The following is a description of a gene set: species: Mus musculus Mouse Gene Set: GOBP_GLYCEROLIPID_BIOSYNTHETIC_PROCESS The chemical reactions and pathways resulting in the formation of glycerolipids, any lipid with a glycerol backbone., and this is the list of marker genes: Mppe1, Lpin3, Pik3cg, Ptprq, Etnk2, Pik3cb, Pip4k2b, Sh3glb1, Pigk, Gpat4, Pigt, Dgkg, Apoa2, Ang, Pigc, Apoa1, Dhrs7b, Pip5k1a, Pigx, Pgap1, Lpcat1, Gpld1, Agpat1 (1-acylglycerol-3-phosphate O-acyltransferase 1), Pla2g5, Nr1h3, Agpat3, Ang6, Pigq, Pigw, Ajuba, Pla2g4a, Pck1, Itpka, Alox15 (arachidonate 15-lipoxygenase), Itpkb, Cds2, Rgn (regucalcin), Dgka, Hycc1, Pign, Srebf1, Pdgfa, Mfsd2a, Capn2, Lpin2, Mogat1, Ttc7b, Ptdss1, Tmem150a, Pi4kb, Chkb, Acsl4, Fabp5, Sirt1, Pigg, Lpcat2, Pigm, Plpp1, Pi4k2b, Pld2, Pi4ka, Uvrag, Cds1, Awat2, Itpkc, Dgat1, Mogat2, Piga, Ip6k1, Pigl, Pigh, Pik3r4, Ang5, Dpm3, Far1 (fatty acyl CoA reductase 1), Slc27a1, Abhd8, Etnk1, Pik3c2a, Hdhd5, Pik3ca (NCBI Gene Id 70742), Mboat7, Ldlr, Pcyt1a, Dagla, Agmo, Atm, Crls1, Agpat4, Acsl5 (NCBI Gene Id 71879), Abhd5, Ctdnep1, Efr3b, Gpaa1, Pigo, Pik3r1, Plcg2, Inpp4a, Pgap2, Pdgfb, Pcyt2, Avil, Pyurf, Htr2a, Slc30a5, Thrsp (NCBI Gene Id 21835), Pla2g6, Inpp1, Dgkd, Tcf7l2, Pip4k2c, Scarb1, Pnpla3, Pi4k2a, Lpin1, Pigf, Dgkh, Pisd, Pik3c2b, Lclat1, Selenoi, Tafazzin, Cnep1r1, Gk, Pigu, Chka, Tmx1, Plscr1, Lpl, Pigb, Pip5k1c, Acsl3, Atg14, Rab38, Lpgat1, Tmem68, Gpat3, Ttc7, Pgap4, Pik3c3, Pip4k2a, Cwh43, Becn1, Pigp, Pgap3, Apoc3, Fabp3, Daglb, Pgs1, Pla2g4c, Gpam, Abhd4, Tamm41, Lcat, Dgke, Kat5, Dgkq, Impa1, Plscr3, Nr1h2, Gpat2, Sh3yl1, Acsl1, Ptpmt1, Plin5, Inpp4b, Dgat2, Agpat5, Pik3c2g, Lpcat3, Vac14, C3, Pigs, Dpm2, Pip5kl1, Bpnt1 (3'(2'), 5'-bisphosphate nucleotidase 1), Ip6k3, Ptdss2 (NCBI Gene Id 27388), Bscl2, Pnpla2, Sik1, Dgkb, Smg1, Pik3cd, Nr1h4, Impa2, Rbp2, Pigz (phosphatidylinositol glycan anchor biosynthesis, class Z), Pemt, Dgkz, Ip6k2, Cln3, Pld1, Inpp5e, Dgkk, Htr2b, Pck2, Pla2g15, Hycc2, Cdipt, Pigv, Agpat2, Pigyl (NCBI Gene Id 66268), Plce1, Cept1, Fgf7, Bpnt2, Dgat2l6, Fig4, Ang4, Dpm1, Dgki, Ang2, Acsl6, Pip5k1b, Chpt1, Inppl1, Pcyt1b, Htr2c